Given this list of marker genes MAP3K5, TP73, RFC3, HSP90B1, AURKA, CD9 (CD9 molecule), CCND1, SERPINF2, CCNO, PLPPR4, FGF2, TP53BP2, BAK1, ENO2, MAP3K14, CCNE2, VEGFB, GRAMD4, FGFR3, PAWR, CCNE1, CFLAR, TNFSF9, IFNA2, ARHGAP4, RAD52, MMP16, BID, BAD, here is a description of the gene set: The p16/RB/E2F regulatory pathway, which controls transit through the G1 restriction point of the cell cycle, is one of the most frequent targets of genetic alterations in human cancer. Any of these alterations results in the deregulated expression of the transcription factor E2F, one of the key mediators of cell cycle progression. Under these conditions, E2F1 also participates in the induction of apoptosis by a p53-dependent pathway, and independently of p53. Recently, we identified the p53-homolog p73 as a first direct target of p53-independent apoptosis. Here, we used a cDNA microarray to screen an inducible E2F1-expressing Saos-2 cell line for E2F1 target genes. Expression analysis by cDNA microarray and RT-PCR revealed novel E2F1 target genes involved in E2F1-regulated cellular functions such as cell cycle control, DNA replication and apoptosis. In addition, the identification of novel E2F1 target genes participating in the processes of angiogenesis, invasion and metastasis supports the view that E2F1 plays a central role in many aspects of cancer development. These results provide new insight into the role of E2F1 in tumorigenesis as a basis for the development of novel anti-cancer therapeutics. Genes up-regulated by induction of E2F1 expression in Saos2 (osteosarcoma) cells. species: Homo sapiens from publication Stanelle J, Stiewe T, Theseling CC, Peter M, Pützer BM (PMID 11937641) Human Gene Set: STANELLE_E2F1_TARGETS